The following is a description of a gene set: Reactome Pathway: Defective SLC34A3 causes Hereditary hypophosphatemic rickets with hypercalciuria (HHRH) SLC34A3 is almost exclusively expressed at the apical membranes of kidney proximal tubules and encodes a Na+/Pi cotransporter. It cotransports 2 Na+ ions with every phosphate (Pi) (electroneutral transport). Defects in SLC34A3 are the cause of hereditary hypophosphatemic rickets with hypercalciuria (HHRH; MIM:241530), an autosomal recessive form of hypophosphatemia characterised by reduced renal phosphate reabsorption and rickets. species: Homo sapiens part of: SLC transporter disorders, and this is the list of marker genes: SLC34A3